The following is a description of a gene set: Human Gene Set: GOBP_NEGATIVE_REGULATION_OF_PROTEIN_BINDING Any process that stops, prevents, or reduces the frequency, rate or extent of protein binding. studied in species Homo sapiens, and this is the list of marker genes: PSME3IP1, USP33, IFIT2, CFHR2, IFIT1, MIR27B (NCBI Gene Id 407019), SLPI, LRPAP1, TLE5, ITGB1BP1, PEX14, CAMK1, EFHB, MITD1, PTPRF, CARD18, ITGA4, CTNNBIP1 (NCBI Gene Id 56998), GNL3L, DDX11 (NCBI Gene Id 93260), NES, ROCK1, MAPK8, PIN1, XIRP1, CARD16, GTF2F1, CSNK1E, DNAJB2, SYMPK, IL10, DACT1, GOLGA2, RALB, STYX, CFHR1, ADIPOQ, AURKA, BAX, RACK1, MIR148A, ADAM15, TMC8, CFHR5